The following is a description of a gene set: Mouse Gene Set: MIR_6982_5P Genes predicted to be targets of miRBase v22 microRNA mmu_miR_6982_5p in miRDB v6.0 with MirTarget v4 prediction scores > 80 (high confidence targets). from publication Chen Y, Wang X (PMID 31504780) species: Mus musculus, and this is the list of marker genes: Lenep, Cabp5, Aspm, Kcnk18, Man1a2 (mannosidase, alpha, class 1A, member 2), Eef2k, Sbk3, Gtpbp1, Ankrd45, Aqp3, Smchd1, Spata3, Hmgxb3, Timp1, Nhsl2, B3gnt6, Calm2, Usp27x, Hacd2, E2f3, Sema3c, Krt19, Camk1d, Nfyb, Gucy1a2, Luc7l2, Ppp2r3a, Trim9, Necap1, Tnfrsf11a, Ocrl, Ccl28, Sirt1, Tiam1, Ltbp1, Cpped1, Lrrc59, Gstm2, Nim1k, Ltb4r2, Bean1, Fxr1, Tigd4, Frmd7, Clvs1, Scamp2, Stx3, Relch, Txnrd1 (thioredoxin reductase 1), Ets2, Mat2a, Grik1, Prrt3, Zfp174, Septin1, Dnajc13, Ctbs, Wasf1, Vsnl1, Mid1ip1, Card10, Mrps33, Prkce, Dock5, Shisa6, Cpsf7, Ywhab, Serpina1f, Mansc1, Serpinb5 (NCBI Gene Id 98414), Agpat4, Ptchd1, Pex13